Given this list of marker genes FKBP14, FGFR3, PPIB (peptidylprolyl isomerase B), TNFRSF1A, COMP, LMX1B, MEFV, B3GALT6, here is a description of the gene set: The capability that a large joint (or a group of joints) has to move, passively and/or actively, beyond normal limits along physiological axes. Large joints include shoulders, elbows, hips, knees, and ankles. studied in species Homo sapiens Human Gene Set: HP_LARGE_JOINT_HYPERMOBILTY Large joint hypermobilty